The following is a description of a gene set: species: Mus musculus Mouse Gene Set: GOBP_FATTY_ACID_TRANSPORT The directed movement of fatty acids into, out of or within a cell, or between cells, by means of some agent such as a transporter or pore. Fatty acids are aliphatic monocarboxylic acids liberated from naturally occurring fats and oils by hydrolysis., and this is the list of marker genes: Apoe, Fabp12, Pla2g12b, Tmem135, Slc25a17, Pla2g1b, Acacb, Cyp4a32, Nmb, Akt2, Nos2, Avpr1b, Abcd1, Thbs1, Oc90, Fabp6, Slc22a2, Repin1, Cyp4a31, Anxa1, Fabp3, Rps6kb1, Lhcgr, Pla2g4a, Fabp7 (fatty acid binding protein 7, brain), Sstr4, Slc27a4, Abcc1, Pla2g4f, Pla2g2a (phospholipase A2, group IIA (platelets, synovial fluid)), P2rx7, Fabp2, Tnfrsf11a, Abcc4, Slc22a1, Slc22a7, Plin2, Hrh2, Slc27a2, Pla2r1, Acsl5, Atp5pf, Proca1, Crabp1, Ptgs2, Spx, Abcc2 (NCBI Gene Id 12780), Mapk9, Akt1, Map2k6, Cpt1b, Bdkrb2, Mfsd2a, Pla2g5, Fabp1, Rbp2, Pla2g10, Slco2a1, Drd4, Kiss1r, Il1a, Hnf1a, Slc2a1, Pla2g2c, Pla2g2e, Acsl3, Slco4a1, Acsl4, Il1b, Ucp2, Slc43a3, Pnpla8, Slco3a1, Crabp2, Pla2g2d, Cyp4a10, Abcd2, Nmur2, Eprs1, Abcd4, Cpt2, Pmp2, Erfe, Mif, Pparg, Slc27a1, Acsl6, Pla2g12a, Fabp5, Agtr2, Lypla1, Drd3, Pla2g3, Pla2g2f, Ptges, Ppard, Slc22a6, Fabp4, Rbp1 (retinol binding protein 1, cellular), Lep, Edn1, Cd36, Abcd3, Rbp7, Fabp9, Tnfsf11, Ntsr1, Irs2, Slc25a20, Drd2, Crot, Pla2g6, Slc27a5, Slc27a3, Slc5a8, Slc27a6, Slc22a22, P2ry2, Ace, Lyn, Oxt, Slc22a8, Got2, Syk, Hrh3 (histamine receptor H3), Kcnj8, Acsl1, Fis1